The following is a description of a gene set: Human Gene Set: MIR6716_5P studied in species Homo sapiens Genes predicted to be targets of miRBase v22 microRNA hsa-miR-6716-5p in miRDB v6.0 with MirTarget v4 prediction scores > 80 (high confidence targets). from publication Chen Y, Wang X (PMID 31504780), and this is the list of marker genes: JMJD7-PLA2G4B, KCNMA1, POPDC3, PLEKHA8, QRFPR, RPL27A, ABCB7, CHRNG, TNFSF13, CEP85, CPED1, ARF3, GRAMD1B, CMTM5, TP53INP2, MTCL2, DNAAF3, CITED2, PKN2, RNF111, AP1G1, CRIM1, ETNK2, NUP50, LPAR1, ARGLU1, PRDM2, ZNF597, SLC25A17, EBF2, RCAN2, RALYL, MKRN2, ZNF335, SAP130, WBP1L, SHQ1, SYT11, CLEC3A, AP1S1, RSPO3, UST, PLAGL2, EML5, DCTN4, CYP11B1, NR3C1, PHACTR2, PDYN, TNFSF12-TNFSF13, TRIM31, SRSF1, ETV5, PAXBP1, FAT3, CLDN7, TMEM178B, ZNF500, SH3BGRL, ZWINT, TNRC6B, LARGE1, TUBGCP4, RNF38, STXBP5L, NIPBL, RAN (NCBI Gene Id 87046), DTX4, ANKIB1, C19orf84, AADACL4, TWSG1, ZNF264, PCK1, ATXN1, TRERF1, GK5 (glycerol kinase 5), ENKUR, FIZ1, PDE3B, TTC19, AMOTL2, SLC30A7, UBA6, BBX, MYRIP, NFE2, SV2B, TAGLN2, SH3BP5L, SPRY3, HAGH, ASXL3, KDM5C, HSPA1L, TLCD3A, COL17A1, TGIF1, TCF4, SMAD2, P2RY8, SENP7, HYDIN, AMT, TCF7L2, NR2C1, UPRT, HS3ST1, KLHL42, MCTP1, MICU3, AMPH, ST8SIA3, POGK, AKTIP, SRGAP1, RARB, ARFIP1, ATXN7L3, SLC39A14, SGCD, BCLAF3, ICMT, PLA2G4B, ZNF827, METTL9, GMNC, MBNL3, LRRC8A